Given this list of marker genes XPNPEP2, CHD7, CDSN, CBL, FH, ROS1, STAT3, CYP4F22 (NCBI Gene Id 50992), ATP8B1, BRCA2, SLCO1B1, EPAS1, KLK11, GPR35, ALOXE3, ST14, RUNX1, MIA3, PNPLA1, CLEC7A, ALOX12B, CARD14, IRF5, ATP7B, SULT2B1, CST6, LRP1 (LDL receptor related protein 1), LIG4, ASXL1, RAG1, IL2RG, HSD3B7, IL7R, MMEL1, GSN, CERS3, ZFYVE19, FDPS, TRPV3, MED12, DCDC2, POU2AF1, IL31RA, DCLRE1C, ATP2A2, VPS33B, TNFSF15, KIF12, LBR, PKHD1, RAG2, SEMA4D, CTLA4, OSMR, LIPN, IL12RB1, NLRP3, CD28, RMRP, LIPA, NIPAL4, ABCB4, DNASE1L3, PDGFRA, POGLUT1, TRPM4, MST1, HLA-DRA, CFTR (CF transmembrane conductance regulator), VIPAS39, PKP1, KRT5, CLDN1, FECH, SOX5, KRT10 (NCBI Gene Id 3858), TNFRSF1B (TNF receptor superfamily member 1B), CTNNB1, HLA-DQB1, TJP2, PSENEN, ADA, SEMA7A, ASPRV1, MPL, IL17F, UNC45A, SDR9C7, CCDC47, RAF1, PEPD (peptidase D), MVK, UROS, GATA1, HLA-DRB1, FLG2, STX3, DSG4, SCN11A, PMVK, ABCA12, SLCO1B3, ABCB11, ZNF341, TGM1, IL17RA, PTPN3, IL12A, KIT, BRCA1, AQP5, NRAS, FLI1, PPP1R13L, EPOR, SCN10A, THPO, SLC17A9, TRAF3IP2, SPIB, BRAF (NCBI Gene Id 673), TNPO3, PLEC, SCN9A (sodium voltage-gated channel alpha subunit 9), PLCG2, NR1H4, CAST, POFUT1, IL17RC, PERP, KRT14, SRSF2, JAK2, USP53, LDHA (lactate dehydrogenase A), TCF4, KRT74, DSP, MYO5B, ALK, UROD, TET2, COL7A1, MVD, GPNMB, ZEB2, SLC27A4, here is a description of the gene set: Pruritus is an itch or a sensation that makes a person want to scratch. This term refers to an abnormally increased disposition to experience pruritus. studied in species Homo sapiens Pruritus Human Gene Set: HP_PRURITUS